Given this list of marker genes Acss2, Thnsl2, Acot4, Oxsm, Ces1d, Mmut, Acss1, Crat, Pck1, Phyh, Acot9, Pck2, Ces1f, Acads, Tyrp1, here is a description of the gene set: Mouse Gene Set: GOBP_SHORT_CHAIN_FATTY_ACID_METABOLIC_PROCESS The chemical reactions and pathways involving a short-chain fatty acid. A short-chain fatty acid has an aliphatic tail containing fewer than 6 carbons. species: Mus musculus